The following is a description of a gene set: Mouse Gene Set: GOBP_AMACRINE_CELL_DIFFERENTIATION The process in which a relatively unspecialized cell acquires specialized features of an amacrine cell, an interneuron generated in the inner nuclear layer (INL) of the vertebrate retina. Amacrine cells integrate, modulate, and interpose a temporal domain in the visual message presented to the retinal ganglion cells, with which they synapse in the inner plexiform layer. Amacrine cells lack large axons. species: Mus musculus, and this is the list of marker genes: Gdf11, Rorb, Neurod1 (neurogenic differentiation 1), Foxn4, Barhl2 (BarH like homeobox 2), Tgif1 (TGFB-induced factor homeobox 1), Fat3, Tgif2, Casz1, Hes1, Bhlhe22, Ikzf1, Pou4f2, Ptf1a, Dlx2, Dlx1, Miat, Neurod4 (NCBI Gene Id 11923)